The following is a description of a gene set: Genes predicted to be targets of miRBase v22 microRNA mmu_miR_3058_3p in miRDB v6.0 with MirTarget v4 prediction scores > 80 (high confidence targets). Mouse Gene Set: MIR_3058_3P from publication Chen Y, Wang X (PMID 31504780) species: Mus musculus, and this is the list of marker genes: Phactr3, Msh3, Elfn2, Saraf, Marchf6, Ephb1, Sh3pxd2a, Zbtb8b, Gcnt2, Selenow, Adarb2, Ntrk2, Blmh, Tead2, Ube2q2, Zfp827, Brcc3, Fzd3, Srgap3, Ppara, Fgf13, Fbxw11, Fyco1, Limk1, Moap1, Kcna7, Nr3c1, Npas2, Vwc2l, Smg6, Tm9sf4, Nsg2, Vip, Plagl1, Suclg2, Dnmt3a, Ackr4, Atp1b4, Rdm1, Prex2, Fxyd4, Ubn2, Ubl4b, Csmd3, Zdhhc15, Srsf3, Ripk4 (NCBI Gene Id 72388), Psg16, Ddi2, Adam9 (ADAM metallopeptidase domain 9), Zhx1, Mr1, Rnf150, Hsp90aa1, Bace1, Col11a1, Ccdc178, Myoz3, Mbnl2, Gria2 (glutamate receptor, ionotropic, AMPA2 (alpha 2)), Hnrnpa3, Hspd1, Fnip1, Gtf2a1, Cdk4, Daam1, Degs2, Epb41l1, Cbx6, Actr3, Lamtor3, Csf2ra, Tmem170b, Edaradd, Acsl3, Tnpo3, Eif4ebp1, Chmp1b2, Slc36a2, Nfatc1, Plxna4 (NCBI Gene Id 330281), Elavl1, Actr2, Pigk, Trmt12, Aak1, Ermap, Zfp964, Mb21d2, Kcnh1, Pdha1, Srp72, Parm1, Cmtr2, Tars3 (NCBI Gene Id 272396), Atp8b1, Mtm1, Rnd1